The following is a description of a gene set: Replacement of protamines by nucleosomes in the male pronucleus species: Homo sapiens Human Gene Set: REACTOME_REPLACEMENT_OF_PROTAMINES_BY_NUCLEOSOMES_IN_THE_MALE_PRONUCLEUS, and this is the list of marker genes: H4C4, H2BC1, H4C3, H4C16, H4C12, PRM2, H3-3B, H1-8 (NCBI Gene Id 132243), HIRA, H2BC26, H4C9, H2BC11, PRM1, H4C8, H4C5, H2AX, H2BC14, H2BC4, H2BC12L, H4C2, H2BC8, H2BC7, H2BC5, H2BC15, H4C1, H4C11, H4C13, NPM2, H2BC17, H2BC3, SRPK1, H4C6, H2BC13, H4C15, H2BC6, METTL23, H3-3A, H2BC12, H4C14, H2BC9, H2BC10, H2BC21